The following is a description of a gene set: Mouse Gene Set: GOBP_REGULATION_OF_CALCIUM_ION_DEPENDENT_EXOCYTOSIS_OF_NEUROTRANSMITTER studied in species Mus musculus Any process that modulates the frequency, rate or extent of calcium ion-dependent exocytosis of neurotransmitter., and this is the list of marker genes: Rab3a (NCBI Gene Id 19339), Syt1, P2rx7, Unc13b, Atp2a2, Rab3gap1